Given this list of marker genes MIR339 (microRNA 339), IQGAP3, RNF41, OCA2, DGKA, CEROX1, RNU6-256P, SLC6A13 (NCBI Gene Id 6540, solute carrier family 6 member 13), TRIM41, ZDHHC14, FCMR, here is a description of the gene set: from publication Yevshin I, Sharipov R, Kolmykov S, Kondrakhin Y, Kolpakov F (PMID 30445619) Human Gene Set: MNX1_TARGET_GENES Genes containing one or more binding sites for (MNX1) in their promoter regions (TSS -1000,+100 bp) as identified by GTRD version 20.06 ChIP-seq harmonization. species: Homo sapiens